Given this list of marker genes Gsk3b, Hook3, Nin, Bicd1, Cep19, Bicd2, Ninl, Map1s, Ccdc68, Dctn1 (dynactin 1), Ccdc120, Kif3a (NCBI Gene Id 192824), Bbs4, Pcm1, here is a description of the gene set: Mouse Gene Set: GOBP_MICROTUBULE_ANCHORING_AT_MICROTUBULE_ORGANIZING_CENTER Any process in which a microtubule is maintained in a specific location in a cell by attachment to a microtubule organizing center. species: Mus musculus